Given this list of marker genes MAPK8IP1, NCKAP1L, IRF1, HFE, SH3RF1, XCL1, ZBTB7B, HLA-A, DAPL1, CD274, VSIR, HLA-E, LILRB4, SOCS1, RUNX3 (RUNX family transcription factor 3), RUNX1, CBFB, LILRB1, SLC4A2, CRTAM, here is a description of the gene set: Any process that modulates the frequency, rate or extent of CD8-positive, alpha-beta T cell activation. studied in species Homo sapiens Human Gene Set: GOBP_REGULATION_OF_CD8_POSITIVE_ALPHA_BETA_T_CELL_ACTIVATION